The following is a description of a gene set: Mouse genes annotated to increased pancreas tumor incidence (MP:0009153) retrieved from the Mouse Genome Informatics database via MouseMine species: Mus musculus Mouse Gene Set: MP_INCREASED_PANCREAS_TUMOR_INCIDENCE from publication Motenko H, Neuhauser SB, O'Keefe M, Richardson JE (PMID 26092688), and this is the list of marker genes: Nsmce2, Myc, Gcgr, Sirt2, Ndrg2, Trp53, Tnk1, Kras, Men1, Pcsk2